The following is a description of a gene set: from publication Chen Y, Wang X (PMID 31504780) Genes predicted to be targets of miRBase v22 microRNA hsa-miR-4427 in miRDB v6.0 with MirTarget v4 prediction scores > 80 (high confidence targets). Human Gene Set: MIR4427 studied in species Homo sapiens, and this is the list of marker genes: PIGX, GUF1, TMPRSS11B, MOCS3, PANX1, CBR4, GABRA4, ABL2, MAGEA6, C1QTNF9B, SNX9, KCTD12, PDE4D, CFH, UBR3, ZDHHC21, VAT1L, MAGEA12, HS2ST1, CFAP90, RNF217 (ring finger protein 217), ZEB2, SFXN1, ABCG2, PDCD7, NRK, LGALSL, TMEM167A (transmembrane protein 167A), UBE2K, CHM, CEACAM1, RPS20, CEP57, SRSF1, SLC38A1, PRRC2C, ARID1B, YIPF6, IL6ST, OR51E1, VAPB, CNTD1, PNISR, TSPAN12, CCNG2, ENSG00000266560, ZMIZ1, MAGEA2, SANBR, B4GALNT4, CHMP4B, ZNF81, BFAR, HAND2, ARHGAP36, CLMP, FAM169A, MACF1, LHFPL5, PAK3, ELAVL2, SPHKAP, JAG2, TOB2, SLC2A1, FAM177A1, BDNF, ANKS1A, EFCAB13, ZNF395, PTBP3, FCHO2, PAX7, SOCS3, TANC1, PM20D2, HS3ST5, POU3F3, CRELD2, SUCO, RIMOC1, GOLIM4, NRG3, BNC1, VCPIP1, ATAD5, HAPLN1, COBLL1, UBE2E1 (ubiquitin conjugating enzyme E2 E1), SPTLC2, TNRC6B, SLC38A2, ZNF521 (NCBI Gene Id 25925), RASSF3, ZNF250, BTAF1, RNF14, NIPAL1, UBXN2B, C2orf69, TSPAN9, TET3, TBC1D13, BEND7, GPATCH2L, PALLD, RNF6, SEM1, ABCB10, CFAP97, UBE3D, PRTG, CFHR1, LRRTM3, NEUROD6 (neuronal differentiation 6), PUM2, NUFIP2, FBXO11, CACNA2D1, FUT9, PPM1B, GNS, EYA4, HEY2, DTWD2, UBE2W, MAGEB16, JADE1, MXI1, OLAH, ZC3H12A, ARID4A, PCDH9, GOLT1B, SPTY2D1, TMEM168, TBC1D4, SORBS1, TARDBP, ADARB1, DNPEP, SYTL5, MAGEA5P, PCSK2, SPMIP1, RNF4, TCAF1, ZFY (NCBI Gene Id 7544), CDC20B, ZNF678, ZNRF2, CP, SLC10A7, LNPK, NDP, BBX, GID4, ADAMTSL3, SLC17A3, MSI1, MARK1, ANKRD17, FAM111B, PCSK1, KLHL24, TFAP2A, WDR20, CGN, B3GALNT2, FOXN1, SLC24A2, RFX7, PACSIN2, DCP2, PCBD2, BCCIP, CADPS, HEG1, RB1CC1, ERRFI1, TNPO1, RBM46, FPR2, GDAP2, FBXO30, CASP7, MBNL2, CIT, ZPBP, TXLNG, COX11, CLOCK, SHE, SUPT6H, GSKIP, DENND4A, SNRK, TRIO, CYCS, NKAIN2, EPB41L4B, NCAPG, MBNL1, ACKR3 (NCBI Gene Id 57007), MAGEA2B, NR2F2, SCML1, SSBP2, TRAPPC13, KIAA0232, SYCP1, C1orf74, CDC40, MEA1, DGKE (NCBI Gene Id 8526), RAPH1, RALGPS1, PRR27, MAGEA4, ENPEP, PBX1, FNDC3B, CAVIN2, METTL13, ARID1A, TGFBR1, KALRN, PMAIP1, FIGN, NDEL1, STRN, ENOPH1, CNOT9, MAML3 (NCBI Gene Id 55534), ZBTB2, GRPEL2, MEF2A, FZD3, ARMC8, LIN9, CYTH3